The following is a description of a gene set: Reactome Pathway: Interleukin-18 signaling electronically inferred by orthology from the curated human pathway This event has been computationally inferred from an event that has been demonstrated in another species.<p>The inference is based on the homology mapping from PANTHER. Briefly, reactions for which all involved PhysicalEntities (in input, output and catalyst) have a mapped orthologue/paralogue (for complexes at least 75% of components must have a mapping) are inferred to the other species. studied in species Mus musculus part of: Interleukin-1 family signaling, and this is the list of marker genes: Il18rap, Il18bp, Il18r1